The following is a description of a gene set: Human Gene Set: TEL2_Q6 Genes having at least one occurrence of the motif YTACTTCCTG in the regions spanning 4 kb centered on their transcription starting sites. This matches the ETV7 transcription factor binding site V$TEL2_Q6 (v7.4 TRANSFAC). species: Homo sapiens, and this is the list of marker genes: MARK1, NXT2, RGS14, SLU7 (NCBI Gene Id 10569), E2F5, FXYD5 (FXYD domain containing ion transport regulator 5), ATL3, RIN3, CLINT1, VAMP8 (vesicle associated membrane protein 8), HM13, LTBR, PSMD13, EXOC5, ARRB2, TNS2, CTSW, CORO1C, CD3E, EDEM3, JPH4, SCAMP2, SEMA4C, CNTROB, OGG1, ING4, SPIB, GMPR2, MEIS1, SLC39A9, CD247, CAP1, RALB, GFI1, CSGALNACT2, AGAP2, STX11, INO80E, CCDC85B, CAPZA1, PALB2, TNRC6A, KLHL20, HYAL2, DMTF1, PPIL1, TMEM185A, ARHGAP15, IKBKB, SOX14, STAT4, MIDEAS, TUSC3, UGGT2, ZKSCAN5, PIK3R4, INTS3, RNPS1, PRKACB, RNF6, DAPP1, ELK4, WDFY4, TMEM138, LYN, SLC25A5, ARHGEF7, SUPT4H1, MRPL52, LSR, JUNB, FOXN3, ZMAT3, CLEC4D, C2CD2L, CYB561A3, RHOV, TRAPPC1, SEC24C, CLMN, ARHGAP45, SMAP2, MGAT4A, IL23A, CGGBP1, HOXC4, POU3F4, NHERF1, SF3B4, GGT7, FCHO1, PIH1D1, DNAJC14 (DnaJ heat shock protein family (Hsp40) member C14), ZNF408, DDX50, ZBTB41, ZNF668, ST7L, ZNF646, CKS1B, U2AF2, PYROXD1, TGIF2, ABCA1, UBE2N, LYRM1, TCF12, GTSF1, HBEGF (heparin binding EGF like growth factor), ERCC6, C1QTNF6, CHD2, GRB7, HMGA1 (high mobility group AT-hook 1), AMD1, MPZL3, LAYN, ISCU, SLC30A7, SNX1, ITFG1, PSMC2, MSANTD2, LPCAT4, ARAP1, CD2BP2, RUNDC3A, MAP4K2, ZNF768, RAB43, NEDD8, CD79A, LYPLA2, PRKACA, ESRRA, RGS3, SNRPB, TIMM10B, RPF1, POLL, SLC39A11, PNMA1, TAF8, NR4A2, ERH, TRIM41, DEPDC4 (DEP domain containing 4), NASP, INO80, KDF1, PTPN6, DCTN5, ALDH16A1, HCLS1, FBXO22, PYM1, CCL2, MED26 (NCBI Gene Id 9441), TMEM71, SYVN1, FIBP, FURIN, HERC4, DGKA, MINDY1, ARHGAP1, INO80B, TAF5, TMEM69, PAFAH1B2 (NCBI Gene Id 5049), DCUN1D3, RIPOR1, MAP3K11, CHMP1B, APPL2, SART3, NIPAL2, LIME1, BTAF1, DNAAF8, CAST, ARFIP2, STARD13, CTTNBP2NL, USP3, CD40LG (NCBI Gene Id 959), ZDHHC5, AGPAT1, RINL, BIN3, NR1D1, CANX, CTSS, ZNF384, CIAO2A, PTK2, TIMM10, KAT5, ARHGAP4, SIRT3, ANKS3, MUSK, AP5M1, VPS25, RIN1, DPP3, PPP4C, NDUFS2, ZMYND8, CPNE8, PLCG1, ZNF800, AGL, CSAD, SIPA1, ACSL5, MCRS1, ADAMTS4, RLIM, DES, DPCD, TRMT2B, LCP1, TEAD3, CTR9, HIRIP3, EXTL2, ZNF687, LIN28A, DCLRE1C, CASP8, TFE3, SHC1, DIABLO, MARK3, HSP90B1, DPPA4, DDIT3, IL11RA, CMTM6